Given this list of marker genes STC1, THBS3, ATF2, TGFBR2, SOX9, MMP13, RARG, POC1A, IFT80, NPR2, TSKU, FOSL2, CER1, RARB, COMP, COL27A1, POR, MATN1, RARA (NCBI Gene Id 5914), ZMPSTE24, NPPC, here is a description of the gene set: studied in species Homo sapiens Human Gene Set: GOBP_GROWTH_PLATE_CARTILAGE_DEVELOPMENT The process whose specific outcome is the progression of the cartilage that will provide a scaffold for mineralization of endochondral bones as they elongate or grow.